The following is a description of a gene set: species: Homo sapiens Neurotransmitter disorders Human Gene Set: WP_NEUROTRANSMITTER_DISORDERS, and this is the list of marker genes: DDC, COMT, SLC6A3, PNMT, DBH, TPH1, TPH2, SLC18A2, MAOA, TH